The following is a description of a gene set: Any process that stops, prevents or reduces the frequency, rate or extent of calcium ion transmembrane transport via high voltage-gated calcium channel. studied in species Homo sapiens Human Gene Set: GOBP_NEGATIVE_REGULATION_OF_CALCIUM_ION_TRANSMEMBRANE_TRANSPORT_VIA_HIGH_VOLTAGE_GATED_CALCIUM_CHANNEL, and this is the list of marker genes: MIR328, REM1, BIN1, SESTD1, UBR3